The following is a description of a gene set: Human Gene Set: GOBP_CALCIUM_ION_EXPORT_ACROSS_PLASMA_MEMBRANE species: Homo sapiens The directed movement of calcium ions from inside of a cell, across the plasma membrane and into the extracellular region., and this is the list of marker genes: SLC8A2, CALM1, CALM2, SLC24A4, CALM3, ATP2B1, YWHAE, RGS9, ATP2B3, SLC8A3, SLC35G1, MIR1-1